The following is a description of a gene set: Human Gene Set: GOBP_REGULATION_OF_GAMMA_AMINOBUTYRIC_ACID_SECRETION studied in species Homo sapiens Any process that modulates the frequency, rate or extent of the regulated release of gamma-aminobutyric acid., and this is the list of marker genes: ABAT, NTSR1, GABBR1, P2RX7, TRH